Given this list of marker genes Cnih4, Epha4, Slc16a2, Chsy1, Lpar4, Man1a2, Rbpj, Casz1, Elavl4, Ahr, Sec24a (SEC24 homolog A, COPII coat complex component), Ankrd40, Col5a1 (collagen, type V, alpha 1), Trim33, F10 (coagulation factor X), Kcnab1, Mier3, Ube2e2, Rb1cc1, Hnf1b, Cacng2, Gpr34, Slc38a2, Gphn, Dip2c, Golph3, Ccdc73, Ywhaz, Fzd8, Unc5d, Atxn7, Spag9, Fut8, Ppp2r2a, Wbp1l, here is a description of the gene set: Genes predicted to be targets of miRBase v22 microRNA mmu_miR_375_3p in miRDB v6.0 with MirTarget v4 prediction scores > 80 (high confidence targets). Mouse Gene Set: MIR_375_3P from publication Chen Y, Wang X (PMID 31504780) species: Mus musculus